Given this list of marker genes PPIB, ZFYVE1, EEF1A1, NUCKS1, VAPA, STOM, YTHDC2, PIK3C3, TBC1D20 (NCBI Gene Id 170488), VAPB, here is a description of the gene set: A process in which a host organism activates or increases the frequency, rate or extent of viral genome replication. studied in species Homo sapiens Human Gene Set: GOBP_POSITIVE_REGULATION_BY_HOST_OF_VIRAL_GENOME_REPLICATION